Given this list of marker genes Ndor1, Akr1b8, Mtrr, Srd5a1, Dhfr, Dus2, Nos1, Kcnab1, Cbr4, Kdsr, Hmgcr, Cryz, Qdpr, Cbr3, Cybb, Akr1c21, Fdxr, Decr1, Lbr, Grhpr, here is a description of the gene set: species: Mus musculus Mouse Gene Set: GOMF_NADPH_BINDING Binding to the reduced form, NADPH, of nicotinamide-adenine dinucleotide phosphate, a coenzyme involved in many redox and biosynthetic reactions.